The following is a description of a gene set: The process of introducing a phosphate group to a tyrosine residue of a STAT (Signal Transducer and Activator of Transcription) protein. Human Gene Set: GOBP_TYROSINE_PHOSPHORYLATION_OF_STAT_PROTEIN species: Homo sapiens, and this is the list of marker genes: JAK3, IL18, IL12A, FER, CSF1R, OSM, FLT3, KIT, TNFSF18, IL20, IL15, IFNL1, PTPN2, TNFRSF18, HES1, IL31RA, JAK2, CTF1, IL21, IFNG, PTK6, ERBB4, CNOT7, CNTF, FGFR3, ARL2BP, PARP9, INPP5F, IFNL4, PIBF1 (NCBI Gene Id 10464), PARP14